Given this list of marker genes Hip1r, Gmfb, Pick1, Coro1b, Dnai3, Ctnna2, Gmfg, here is a description of the gene set: species: Mus musculus Mouse Gene Set: GOBP_NEGATIVE_REGULATION_OF_ARP2_3_COMPLEX_MEDIATED_ACTIN_NUCLEATION Any process that stops, prevents, or reduces the frequency, rate or extent of actin nucleation mediated by the Arp2/3 complex and interacting proteins.